The following is a description of a gene set: BACKGROUND: Genome-wide measures of gene expression can identify patterns of gene activity that subclassify tumours and might provide a better means than is currently available for individual risk assessment in patients with lymph-node-negative breast cancer. METHODS: We analysed, with Affymetrix Human U133a GeneChips, the expression of 22000 transcripts from total RNA of frozen tumour samples from 286 lymph-node-negative patients who had not received adjuvant systemic treatment. FINDINGS: In a training set of 115 tumours, we identified a 76-gene signature consisting of genes for patients positive for oestrogen receptors (ER) and genes for ER-negative patients. This signature showed 93% sensitivity and 48% specificity in a subsequent independent testing set of 171 lymph-node-negative patients. The gene profile was highly informative in identifying patients who developed distant metastases within 5 years (hazard ratio 5.67), even when corrected for traditional prognostic factors in multivariate analysis (5.55). The 76-gene profile also represented a strong prognostic factor for the development of metastasis in the subgroups of 84 premenopausal patients (9.60), 87 postmenopausal patients (4.04), and 79 patients with tumours of 10-20 mm (14.1), a group of patients for whom prediction of prognosis is especially difficult. INTERPRETATION: The identified signature provides a powerful tool for identification of patients at high risk of distant recurrence. The ability to identify patients who have a favourable prognosis could, after independent confirmation, allow clinicians to avoid adjuvant systemic therapy or to choose less aggressive therapeutic options. from publication Wang Y, Klijn JG, Zhang Y, Sieuwerts AM, Look MP, Yang F, Talantov D, Timmermans M, Meijer-van Gelder ME, Yu J, Jatkoe T, Berns EM, Atkins D, Foekens JA (PMID 15721472) Genes whose expression in primary ER(+) breast cancer tumors negatively correlates with developing distant metastases. studied in species Homo sapiens Human Gene Set: WANG_METASTASIS_OF_BREAST_CANCER_ESR1_DN, and this is the list of marker genes: OR12D2, GOLM1, ORC3, C3, DUSP4 (dual specificity phosphatase 4), GFOD2, METTL25B, CAPN2, AP2A2, CD44, ARHGDIB, ACACB, NEURL1, EIF4EBP3, IL18, TESPA1, ETV2, NEFL (NCBI Gene Id 4747), BICD1, CNKSR1 (connector enhancer of kinase suppressor of Ras 1), TNFSF13, MMP23B, ABLIM1, TACC2, ZFP36L2, PHF11, LST1, SLC35A1 (NCBI Gene Id 10559), CLN8, MAP4, FKBP2, LINC01482